Given this list of marker genes FLVCR1, CHTF8, URB1, CPT1A, DSCC1, TRAPPC6B, STK40, here is a description of the gene set: Human Gene Set: CAO_BLOOD_FLUMIST_AGE_05_14YO_1DY_UP BACKGROUND: Live attenuated influenza vaccine (LAIV) and trivalent inactivated influenza vaccine (TIV) are effective for prevention of influenza virus infection in children, but the mechanisms associated with protection are not well defined. METHODS: We analyzed the differences in B-cell responses and transcriptional profiles in children aged 6 months to 14 years immunized with these 2 vaccines. RESULTS: LAIV elicited a significant increase in naive, memory, and transitional B cells on day 30 after vaccination, whereas TIV elicited an increased number of plasmablasts on day 7. Antibody titers against the 3 vaccine strains (H1N1, H3N2, and B) were significantly higher in the TIV group and correlated with number of antibody-secreting cells. Both vaccines induced overexpression of interferon (IFN)-signaling genes but with different kinetics. TIV induced expression of IFN genes on day 1 after vaccination in all age groups, and LAIV induced expression of IFN genes on day 7 after vaccination but only in children < 5 years old. IFN-related genes overexpressed in both vaccinated groups correlated with H3N2 antibody titers. CONCLUSIONS: These results suggest that LAIV and TIV induced significantly different B-cell responses in vaccinated children. Early induction of IFN appears to be important for development of antibody responses. Genes up-regulated in blood 1d vs 0d in children (0.5-14y) after exposure to FluMist, time point 1D. Comment: ~80% of cohort were white, ~50/50 Female:male species: Homo sapiens from publication Cao RG, Suarez NM, Obermoser G, Lopez SM, Flano E, Mertz SE, Albrecht RA, García-Sastre A, Mejias A, Xu H, Qin H, Blankenship D, Palucka K, Pascual V, Ramilo O (PMID 24495909)